Given this list of marker genes SOX9, ZFPM2, DMRT1, WT1, WNT4, RETN, GDF9, DHX37 (NCBI Gene Id 84742), NUPR1, SRY, NR5A1, INSR, CITED2, here is a description of the gene set: species: Homo sapiens Human Gene Set: GOBP_REGULATION_OF_GONAD_DEVELOPMENT Any process that modulates the frequency, rate or extent of gonad development.